The following is a description of a gene set: Genes distinguishing asparaginase resistant and sensitive B-lineage ALL; here - genes up-regulated in the drug resistant samples. Childhood acute lymphoblastic leukemia (ALL) is curable with chemotherapy in approximately 80 percent of patients. However, the cause of treatment failure in the remaining 20 percent of patients is largely unknown. from publication Holleman A, Cheok MH, den Boer ML, Yang W, Veerman AJ, Kazemier KM, Pei D, Cheng C, Pui CH, Relling MV, Janka-Schaub GE, Pieters R, Evans WE (PMID 15295046) Human Gene Set: HOLLEMAN_ASPARAGINASE_RESISTANCE_B_ALL_UP species: Homo sapiens, and this is the list of marker genes: RPL3, EEF1B2, CCDC69, IGFBP7, RPS3, EIF3K, RPL4, RPS5, RPL11, H3-3A, RACK1, RPL13A, RPLP0, RPL7A, RPL5, EIF3D, NTRK3, FBL, NOP53, CLEC11A (C-type lectin domain containing 11A), LPCAT1, BCR, EIF3L, TPM4 (NCBI Gene Id 7171), RPL6, EEF1G, TENT5C, GATA3